Given this list of marker genes KIF17, KIF3B, TRAK2, RABGEF1, WASF1, KIF5C, HNRNPU, STAU1, STAU2, RAB17, KIFAP3, KIF5A, KIFC2, FLOT2, SFPQ, PURA, KIF5B, here is a description of the gene set: studied in species Homo sapiens Human Gene Set: GOBP_DENDRITIC_TRANSPORT The directed movement of organelles or molecules along microtubules in dendrites.